Given this list of marker genes Aebp2, Trim37, Tnni3k, Pik3ca, Atr, Foxa1, Oxsr1, Hdac9, Ripk3, Bicral, Padi1, Hmgn2, Hr, Mcm2, Mecom, Eya3, Chd1l, Alpk2, Pbrm1, Dhx9, Kmt2d, Gm4922, Chd9, Jmjd6, Ino80d, Nr3c1 (NCBI Gene Id 14815), Smarca4, Dusp13a, Mir127, Cbx2, Nim1k, Epop, Cdan1, Fbxo30, Piwil1, Hmgb1, Cbx3, Tssk3, Trip12, Ubr5, Mir744, Rbl1, Tada2b, Zfp57, Irf4, Tlk2, Trpm7, 4930402K13Rik, Snai1, Dapk3, Ptpn11 (NCBI Gene Id 72646), Gatad1, Ddb1, Pim3, Eef2kmt (NCBI Gene Id 70511), Ptprg, Cggbp1, Nrde2, Stk39, Ulk3, Tdrd9 (NCBI Gene Id 74691), Eya2, Hltf, H2al1j, Ptp4a2, Prdm8, Fam50a, N6amt1, Aurkc, Ttf1, Ankk1, Kalrn, Eif2ak1, Lmtk3, Pim1, Tada3 (transcriptional adaptor 3), Brsk2, Suv39h1, Pabpc1l, Ppef2, Ksr2, Atg5, Hipk3, H1f7, Nfrkb, Rad54l2, Ezhip, Morf4l1, Airn, Supt4b, Hdac8, H2ac24, Mki67, Gpx1, Ripk1, Bag6, Kdm1a, Cdkn3, Rps6kb1, Padi3, Hmga1, Kmt2a, H3f3a-ps2, Tsix, H2ac4, Usp36, Ddx21, Smyd5, Stk24, Phf1, Phb1, Bub1b, Dusp29, Smarcc1, Zzz3 (NCBI Gene Id 99926), Phlpp2, Brpf1, Parp2, Gtf3c4, Bud23, Trio, Mta3, Sik2, Snai2, Chrac1, Dusp22, Smarcad1, Sphk2, Gm20379, H2ac13, Cdk9, Mthfr, Phkg1, Crebzf, Setd5, Kmt2c, Dicer1, Myo1c, Dnmt3b, Dapk1, Dcaf13, Mier1, Tasor, Sgk3, Bcl7a, Tgm2, Irak4, H2ac19, Nek4, H2al1e, Jade2, Meaf6, Smok3a, L3mbtl4, Sf3b1, Smarcb1, Spin1, Chd3, Ep400, Mastl, Brca1 (breast cancer 1, early onset), Ppm1n, Slk, Lmtk2, Ncor1, Srpk2, Lrif1, Tssk6 (NCBI Gene Id 83984), Cenpa, Mir208b, Alpk1, Smarca1, Dusp21 (NCBI Gene Id 73547), Tet1, Dppa2, Ash2l, Ppp3cc, Tssk1, Smarcd2, Chd4, Hipk4, Dusp26, Gatad2b, Ifi214, Nsd1, Ifi207 (interferon activated gene 207), Ythdc1, Rag1, Clock, Stk17b, Ogg1, Ndn, Apobec1, Mbd3l2 (methyl-CpG binding domain protein 3-like 2), Tnp1, Jade1, Supt6, Rtf1, H2ac25, Mov10, Stk32b, Ppm1j, Dusp8, Wac, Pdik1l, Mbd3l1, Kat6b, Rhno1, Lrrk2, Bptf, Tex15, Upf1, Sycp3, Pkn1, Myo3b, Hipk2, Fam47c, Rif1, Dusp14 (dual specificity phosphatase 14), Lrrk1, Taf1, Ptprc, Ppp6c, Trim28, H2al1n, Rbbp5, Pskh1, Mael, Prdm9, Dek, Mettl3, Pml, Ss18l1, Kdm6a, Ptprf, Tet3, Nsd3, Spty2d1, Npm2, Hdac2, Riok1, Mre11a, Dusp18, Set, Coprs, Tcf3, H2ac15, Mos (Moloney sarcoma oncogene), Sdr16c5, Ppm1m, Ptpn20, Trp53, Top2a, Gnas, Ddx11, Morf4l2, Ppm1b, Dnmt1, Skp1, H3f3c, Lmna, Mndal (myeloid nuclear differentiation antigen like), Tdrd3, Ino80b, Hdac4 (NCBI Gene Id 208727), Ncoa3, 4930480E11Rik (NCBI Gene Id 74910), Stk10, Ppm1l, Dnmt3a, Sbk1, Ptprk, Chaer1 (cardiac hypertrophy associated epigenetic regulator 1), Ptpn2, Ppp3cb, Kdm5b (lysine demethylase 5B), Ptpru (NCBI Gene Id 19282), Pak5, Hdac5, Mycn, Ptpn7, Ttc39aos1, Rccd1, Naa50, Iws1, Cfdp1, Loxl2, Sart3, Apbb1, Tnik, Cdc42bpb, Primpol, Ptprd, Rybp-ps, Tnp2, Topbp1, App, Fam20c, Hnrnpk, Thap7 (NCBI Gene Id 69009), Ppm1f, Rybp, Cdc42bpa, Padi4, Suz12, Nap1l4, Bend2, Pgam5, Ehmt2, Cdk2, Msl3, Mak, 0610010K14Rik, Hdgfl2, Epm2a, Ss18, Zfy2, Ptprm, Taf10, Csnk1g2, Tssk5, Araf, Kat2b, Eef1akmt1, Prmt3 (protein arginine N-methyltransferase 3), Riok2, H2ax, Nuak2, Lmnb1, Ptprq, Ssrp1, Wdr5, Map4k2, Dusp6, Ulk4, Atpsckmt (NCBI Gene Id 68073), Rbbp4, Eya1, Stpg4, Cecr2, Cdc25c, Letmd1, Brd4, Ppm1a, Men1, Tspyl1, Prkcb, Arb2a, Dusp4, Chd5, Mybbp1a (MYB binding protein (P160) 1a), Yeats2, Dusp1, Arid1a, Pik3cg, Uhmk1, Cdyl, Myc, Dnajc9, Ppp1cc, Sbk3, H3f3a-ps1, Ubn1, Rps6kb2, Obscn (NCBI Gene Id 380698), H2ac21, Chaf1b, Bahcc1, Resf1, Hmgn1, Ptp4a1, Mllt6, Eif1, Smg1, Ruvbl2, Usp22, Hunk, Foxa3, Aplf, Map3k19, Kansl2 (KAT8 regulatory NSL complex subunit 2), Tns2, Aurkb (aurora kinase B), Babam2, Taok1, Dclk1, Mta1, Gsk3a, Aak1, Pik3r4, Supt4a, Vcpkmt, Dnajc2, Prkaa2, Piwil2, Huwe1, Prdm16, Ctdp1 (NCBI Gene Id 67655), Fkbp6, Cbx7, Kat6a, Prdm5, Ripk4, Kdm5a, Dapk2, Nr5a2, Cit, Mta2, Pak2, Actl6b, Pak1, Hdac11, Kat2a, Tet2, Ptpn22, Lbr, Ezh1, Per1, Ripk2, Mast1, Hdac3, Ptprr, Rps6ka4, Mast4, Ruvbl1, Glyr1, Nek7, Ubn2, Nfat5, Prmt7, Braf, Rnf2, Mapkapk3, Meg3, Zmpste24, Smok2a, Map4k4, Stk11, Brd9, Msl2, Tspyl5, Map4k3, Rskr, Aurka, Uhrf2, Lcor, Kansl3, Taok3, Hmgn3, Utp3, Prkaa1, M1ap, Eya4, Pcgf1, Ndufaf7, Atf7ip, Cbx8, Setd3, H2al1m, Usp15, Prmt6, Rere, Usp21, Klf2 (Kruppel-like transcription factor 2 (lung)), Setmar, Fbxo24, Cenpn, Atm, Bcorl1, Cdc42bpg, Nasp, Ptpn13, Mbd2, Ppef1, Hpf1, Chd1, Ptpn12, Selenof, Tlk1, Tut4, Prmt2, Ppp5c, H19, Pask, Limk2, Brsk1, Rps6ka3, Mirg, Ogt, Chd6, Crebbp, Chaf1a, Sfmbt1, Pikfyve, Ifi206, Ptpn4, Ikbkb (inhibitor of kappaB kinase beta), Csnk2a1, Tdrd12, Dpf2, Rnf20, Smchd1, Fendrr, Dusp12 (dual specificity phosphatase 12), Fam50b, Prmt9, Tbl1xr1, Jpx, Macroh2a2 (macroH2A.2 histone), Nipbl, Ubash3b, H2al2b, Cilk1, Sirt6, Cdk1, Sfpq, Rbm15b, Ctr9, Ehmt1, Rcbtb1, H2al3, Zfp110, Stk35, Ube2a, Spi1, Nek8, Csnk1e, Kdm4c, Cdc7, Atf2, Kdm5d, Mcrs1, Smarca2, Atxn7l3, Alkbh4, Ntmt1, Dubr, Phf10, Dmpk, Sik1, Mhrt, Hcfc1, Gpx4 (glutathione peroxidase 4), Ern2, Arid1b, Mettl4, Hira, Setd7, Srpk3 (NCBI Gene Id 56504), Usp16, Rpap2, Satb2, Mast2, Snrk (SNF related kinase), Stk3, Kdm1b, Ptprh, Map4k1, Banp, Zfp869, Usp3, Ptma, Myd88, Hdac10, Phf2, Cbx6, Ptpn18, Pptc7, Uhrf1, Bcl6, Tfpt, Baz1a, Mrgbp, Vrk2, Pgp, Brd7, Lhx2, Ctdnep1, Ssh2, Ptpn9, Ptpn23, H1f2, Phf8, Tex19.2, Rnf168, Ncoa1, Pkmyt1, Gatad2a, Csnk1a1, Dcaf1, Zfp827, Mcm3ap, Rbbp7, Map4k5, Nek3, Anp32b, Yeats4, Lats2, Bmyc, Fam47e, a, Psme4, Ssh3, Setdb2, Nat8f3, Rps6ka1, Carm1, Spocd1, Fbl (fibrillarin), Kmt5a, Bcl7c, Ifi213, Bend3, Flicr, L3mbtl2, Ddx4, Dmap1, Chtop, Pim2, H2al1k, Ctcf, Tbr1, Axin1, Btbd18, Actr8, Dusp13b, H1f9, Tex19.1, Dmrtc2, Bcl7b, Ash1l, Mknk2, Tut7, H2al2a, Ncor2, Pdxp, Jak2, Prkdc, Mtf2, H1f0, Prmt5, Sin3a, Cbx1, Nuak1, Trp63, Pax6, Nek6, Kdm3a, Bmi1, Cebpg, Bcor, Dpf1, Nek11, Stk-ps2 (NCBI Gene Id 212225), Jmjd1c, Rsbn1, Trim27, Upf3a, Nucks1, Trpm6, Usp49, Csnk1d, Aicda, Kat8, Bmp2k, Kdm3b, Mphosph8, Supt16, H2az2, Ptpro, H2ac22, Naa40, Epc2, Rad17, Ppm1h, Stk32c, Klf1, Kat14, Ptpn3, Tada2a, Ing5, Mov10l1, Eny2, Phf13, Pwwp2b, Brcc3dc, Stk26, Uchl5, Nudt5, Rlf, Rsl1, Mettl22, Samd7, H4c14, Glmn, Smok2b, L3mbtl3, Pwwp2a, Bmncr, Bahd1, Hmga2 (high mobility group AT-hook 2), Asf1a, Dtx3l, Setdb1, Stk32a, H3f3a, Lats1, Hdac1, Rbl2, Kdm8, Mdp1, Pole3, Taok2, Dclk3, Cenpp, Kpna7, Trp53rkb, Rps6ka2, Suv39h2, Zfp518a, Cdk5 (NCBI Gene Id 12568), Cbx5, Wnk1 (NCBI Gene Id 406236), Smarca5, Ep300, Kdm4b, Nsd2, Tspyl2, Morc1, Mapkapk2, Smyd1, Cdc14a, Mast3, Rps6kc1, Hotair, Smarcc2, Arid2, Atg7, Smyd3 (SET and MYND domain containing 3), Atad2b, Supt5, Prmt1 (NCBI Gene Id 80681), Ptprz1, L3mbtl1, Mllt3, Vps72, H2al1b, Ppp3ca, Ulk2, Pax7, Bicra, Dusp15, Brpf3, Rnf40, Actl6a, Chd2, Dnajc6, Nek9, BC004004, Setd2, Ppp1cb, Reno1, Cenpi, Ppm1d, Ier3ip1, Cdc25a, Ern1, Cdc14b, Mbd3, H2ap, Ciita, Mettl8, Brcc3, Spen, Prm1, Ptprv, Stk38l (serine/threonine kinase 38 like), Rock2, Tspyl4, Akt1, Eef1akmt2, Ptpmt1, Emsy, Csnk2a2, Stk38, Gata3, Chek1, Rela, Dusp2, Csnk1g3, Lin54, Sirt1, Scmh1, Pdpk1, H2ac8, Brd3, Akt2, Mark2, Suds3, Tssk4, Dusp23, Tdrd5, Pak6, Kat7, Kdm6b, Tdg, Eef1akmt3, Nap1l2, Yy1, Pak3, H2aj, Dpf3, Fshr, Kdm2b, Nap1l1, Alkbh1, Ino80e, H2ac12, Atrx, H3f3b, Zfp42, Lsm11, Kmt2b, Asf1b, Wnk3 (NCBI Gene Id 546388), Phf21a, Vrk1, Egr1, Dusp28, Mis18a (NCBI Gene Id 77054), Kcnq1ot1, Ssh1, Mbtd1, Padi2, Usp7, Ring1, Mark1, Bap1, Hipk1, H2ac6, Ttbk1, Akt3, Wt1, Tssk2, Tal1, Ppp2ca, Srpk1, Gsk3b, Nat8f7, Pih1d1, Ctdsp2, Wnk2, H1f3 (NCBI Gene Id 14957), Sycp1, H1f8, Aatk, H2ac7, Kmt2e, Hat1, Ercc6, Nap1l5, Tasor2, Mtmr3, Cenpv, Rps6ka5, Dyrk1a, Rrp8, Mark3, Kmt5b, Zfp462, H2al1o, Stk36, Ssu72, Upf3b, Smok3b, Gm773, Mapkapk5, Haspin, Zdbf2, Itgb3bp, Antkmt, Cpped1, Ctdsp1, Nek10, Mysm1, Znhit1, Ube2b, Mecp2, Top1, Gtf2b, Srcap, Ino80, Rlim, Stk33, Baz2a, Anp32e, Zfp369 (NCBI Gene Id 353071), Cdc25b, Ptprn2, Piwil4, Gnasas1, Pcgf6, Tpr, Chd7, Rad50, H1f6, Ppp1ca, Trrap, Eif2ak4, Kdm4d, H2ac20, Morc2a, Melk, Riox1, Grwd1, Sox9, Prdm6, Tonsl, H3f4, Msl1, Myocd, Ptpn1, Jarid2, Ulk1, Phf19, Znfx1, H2bc1, Ftx, Uty, Pphln1, Uimc1, Brdt, Sbk2, Ifi209, Mtor, Rbm14, Hmg20b, Kdm5c, Ddx23, Lamc1, Kdm2a, Dppa3, Prdm13, Per2, Mark4, Exosc10, Rcor1, Cask, Ppm1g, Pak4, Stk16, Abraxas1, Ilkap, Eomes, Ncoa6, Setd4, Ptpre, Brd2, Apobec3 (apolipoprotein B mRNA editing enzyme, catalytic polypeptide 3), Ublcp1, Pten, Riok3, Parp10, Apex1, Npm3, Lmnb2, Hnrnpu, Stk25, H2ac23, Ttn, Sirt7, Phc1, Ptpn6, Phlpp1, Hmg20a, Kansl1, Bub1, Hcfc2, Mtmr4, Mettl23, Stk40, Dclk2, Ctdspl, Gm38999, Raf1, Asxl1, Rad21, Nfkbiz, Stk31, Hp1bp3 (NCBI Gene Id 15441), Actb, Wbp2, Mcrip1, Irak1, Oip5, Mink1, Foxp3, Jdp2, H2az1, Mknk1, Sik3, Shprh (NCBI Gene Id 70331), Dusp3, Mettl21a, Hmgn5, Limk1, Zmynd11, Zbtb7a, H2al1f, Banf1, Ppp4c (NCBI Gene Id 56420), Nbn, Mbd1, Arid4a, Naa60, Pcid2, Ifi208, Hdgf, Alpk3, Nek1, Ptpn14, H2ac11, H1f5, Dusp19, Bcr, Eed, Smarce1, Cbx4, Eif2ak2, Sgf29, Myo3a, Sgk2, Ctcfl, Psip1, Zfp445, Rnf8, Mylk4, Kmt5c, Prmt8, Dpy30, Ptpn5, Dusp7, Hnf1a, Ppm1k, Gm6421, Rbm15, Tfap2c, Prpf4b, Csnk1g1, Hdac6, Npm1, Htatsf1, Apobec2, Ino80c, Mir136, Pcbp2, Nap1l3 (nucleosome assembly protein 1-like 3), Gak, Morc2b, Hdac7, Ptprb, Wnk4 (WNK lysine deficient protein kinase 4), Pcgf5, Ikzf1, Ptpn21, Ptpra, Stk4, H2ac10, Ttbk2, Arid4b, Ing3, Dot1l, Prdm14, Rian, Fbxl19, Trmt112, Dnmt3l (NCBI Gene Id 54427), Rag2, Eif2ak3, Ifi203, Ubr2, Samd1, Rsf1, Gm7168, Baz1b, H1f1, Hells, Paxip1, Rock1, Chek2 (NCBI Gene Id 50883), Brd8, Dusp10, Ksr1, Smarcd1 (NCBI Gene Id 83797), Ing2, Pcgf3, Zfp518b, Wdhd1, Sgk1, Kdm4a, H2ab1, Chd8, Ppp2cb, H3f5, Ptp4a3, Epc1, Setd1a, Zfp335, Zbtb1, Tbk1, Brca2, Gm10257, Brd1, Rps6kl1 (ribosomal protein S6 kinase-like 1), Setd1b (SET domain containing 1B), Ifi203-ps, Tdrd1, Ezh2, Rps6ka6, Nek5, Hirip3 (NCBI Gene Id 97405), Foxa2, Pkm, Ppm1e, Smyd2, Pink1, Usp51, Nek2, Acp1, Kat5, Phf20, Daxx, Smarcd3, Ptprs, Babam1, Lrwd1, Pwwp3a, H2ac1, Nrk, Ptprj, Mst1, Cdkn1c, Macroh2a1, Mms22l, Satb1, Speg, Hjurp, Kdm7a, Mdc1, Prkx, Ing4, Tox, Tnk2, Rb1, H1f4, H2ab2, 4921509C19Rik, Atad2, Acp3, Ptprt, Actr5, Asz1, Hdgfl1, Sirt2, Rest, H2ab3 (H2A.B variant histone 3), Xist, Mexis, Pcgf2, here is a description of the gene set: Mouse Gene Set: GOBP_CHROMATIN_ORGANIZATION studied in species Mus musculus The assembly or remodeling of chromatin composed of DNA complexed with histones, other associated proteins, and sometimes RNA.